The following is a description of a gene set: studied in species Homo sapiens Reactome Pathway: Interactions of Rev with host cellular proteins In order to facilitate the transport of incompletely spliced HIV-1 transcripts, Rev shuttles between the cytoplasm and nucleus using host cell transport mechanisms. Nuclear import appears to be achieved by the association of Rev with importin-beta and B23 and docking at the nuclear pore through interactions between importin-beta and nucleoporins. The dissociation of Rev with the import machinery and the subsequent export of Rev-associated HIV-1 mRNA complex requires Ran-GTP. Ran GTP associates with importin-beta, displacing its cargo. Crm1 associates with the Rev:RNA complex and Ran:GTP and is believed to interact with nucleoporins facilitating docking of the RRE-Rev-CRM1-RanGTP complex to the nuclear pore and the translocation of the complex across the nuclear pore complex. In the cytoplasm, RanBP1 associates with Ran-GTP causing the Crm1-Rev-Ran-GTP complex to disassemble. The Ran GAP protein promotes the hydrolysis of RanGTP to Ran GDP. The activities of Ran GAP in the cytoplasm and Ran-GEF, which converts RAN-GDP to Ran-GTP in the nucleus, produce a gradient of Ran-GTP/GDP required for this shuttling of Rev and other cellular transport proteins. part of: Host Interactions of HIV factors, and this is the list of marker genes: NUP58, SEC13, NUP133 (NCBI Gene Id 55746), SEH1L, NUP107, XPO1, NUP205, NUP153, NUP188, rev, NUP42 (nucleoporin 42), RAE1, NUP155 (nucleoporin 155), NUP54, RANBP1, NUP93, NUP98, NDC1, NUP43, NUP210, RCC1, RANGAP1, NUP50, AAAS, NUP160, NUP214, NPM1, RAN, NUP85, KPNB1, NUP88, NUP62, NUP35, POM121C, NUP37, TPR, POM121, RANBP2